The following is a description of a gene set: Mouse Gene Set: GOBP_REGULATION_OF_MAST_CELL_DEGRANULATION species: Mus musculus Any process that modulates the frequency, rate, or extent of mast cell degranulation., and this is the list of marker genes: Gab2, D6Wsu163e, Adora2b, Stxbp1, Il13ra2, Fes, Ms4a2, Unc13d (NCBI Gene Id 70450), Sphk2, Gata1, Cd84, Vamp8, Nppc, Adora3, Hmox1, Pla2g3, Gata2, Syk, Pdpk1, Rac2, Pld2, Rabgef1, Il4, Fgr, Snx4, Foxf1 (forkhead box F1), Il13, Fcer1a, Cd300a, Stxbp2, Nppa, Il4ra, Crhr1, Fcer1g, Lyn